Given this list of marker genes Ppp1r15a, Spry2, Dgkq, Ppp2r5d, Grk2, Eif4g1, Spred2, Spred1, Met, Sirt2 (sirtuin 2), Pard3, Ppef2, Dmtn, Smad7, Hnf1a, Ttc36, Ogt, Cadm4, Inpp5k, here is a description of the gene set: studied in species Mus musculus Any process that decreases the frequency, rate or extent of peptidyl-threonine phosphorylation. Peptidyl-threonine phosphorylation is the phosphorylation of peptidyl-threonine to form peptidyl-O-phospho-L-threonine. Mouse Gene Set: GOBP_NEGATIVE_REGULATION_OF_PEPTIDYL_THREONINE_PHOSPHORYLATION